Given this list of marker genes FOXA3, BRCA1, XBP1, SP1, PRDM15, JUN, C4BPB, FOXA2, CEBPB, DSCAM, POU2F1, CYP2C18, TFF1, NFIA, GCG, APOB, PISD, SFTPD, FOS, NFIB, SHH, INS, AP1B1, ATP5PF, NFIC, CREBBP, SERPINA1, NR2F2, SFTPA2, AR, ESR1, NKX3-1, NDUFV3, SCGB1A1, VTN (NCBI Gene Id 7448), FOXA1, KLK3, SOD1, COL18A1, SFTPA1, NRIP1, NCOA3, CDKN1B, EP300, here is a description of the gene set: Human Gene Set: PID_HNF3A_PATHWAY from publication Schaefer CF, Anthony K, Krupa S, Buchoff J, Day M, Hannay T, Buetow KH (PMID 18832364) studied in species Homo sapiens FOXA1 transcription factor network